Given this list of marker genes Oat, Got2, Pycr1, Rimkla, Glul, Aldh18a1, Pycr3, Glud1, Rimklb, Kyat1, Gls, Pycr2, Gls2, here is a description of the gene set: Glutamate and glutamine metabolism Mouse Gene Set: REACTOME_GLUTAMATE_AND_GLUTAMINE_METABOLISM studied in species Mus musculus